The following is a description of a gene set: The part of synaptic transmission occurring in the post-synapse: a signal transduction pathway consisting of neurotransmitter receptor activation and its effects on postsynaptic membrane potential and the ionic composition of the postsynaptic cytosol. Mouse Gene Set: GOBP_CHEMICAL_SYNAPTIC_TRANSMISSION_POSTSYNAPTIC studied in species Mus musculus, and this is the list of marker genes: Igsf9b, Prkar1b, Nlgn1, Dgki, Hcrt, Prkn, Pclo, Grin2c, Celf4, Dbn1, Chrna1, Oprm1, Stx1b, Chrna5, Gabrb3, Slc8a2, Nlgn2, P2rx7, Glra2, Cdk5, Gsk3b, Npy2r, Chrnd, Anks1b, Tmem108, Sh3gl1, Grik2, Unc13b, Bdnf, Eif4a3l2, S1pr2, Eif4a3, Ppp3ca, Wnt7a, Nlgn3, Kcnk2, Ptk2b, Grin2a, Stx1a, App, Adrb1, Npff, Adrb2, Slc29a1, Grin1, Shank1, Dmpk, Ckap5, Chrna7, Glra1, Mef2c, Cacnb3, Neto1, Ppp1r9a, Mecp2, Mpp2, Glra3, Chrng, Ghrl, Prkcz, Baiap2, Grin2d, Chrm5, Ngfr, Grip2, Trpv1, Rims2, Chrna4, Dvl1, Adora2a (NCBI Gene Id 11540), Grik5, Grk2, Slc8a3, Neto2, Chrnb1, P2rx3, Glrb, Chrna6, Rims1, Rgs4, Mtmr2, Igsf11, Nlgn4l, Chrnb4, Lrrk2, Insyn1, Drd4, Dlg4, Pten, Cux2, P2rx2, Cntnap2, Snca, Atxn1, Ntsr1, Begain, Cx3cl1, Chrna2, Eif4a3l1, Chrnb2, Slc17a7, Tmem25, Mapk8ip2, Chrna3, Insyn2a, Afdn, Adora1, Glra4, P2rx4, Sez6, Chrnb3, Grik1, Gria2, Cbln1, Nrxn1, Rab3gap1, Grin2b, Shank3 (SH3 and multiple ankyrin repeat domains 3), Zmynd8, Ssh1 (NCBI Gene Id 384311), Eea1, Grid2, Tbc1d24, Slc1a7, Abat, Reln, P2rx1, P2rx6, Npas4, Fmr1, Gria1, Chrne, Plk2, Notch1, Met